Given this list of marker genes COX7B, APP, COX6A2, COX8A, COX8C, COX4I2, COX6B2, MT-CO1, MT-CO3, COX7A1, COX7A2L, COX7A2, COX6B1, COX4I1, COX5B, COX6A1, COX6C, COX7C, COX5A, MT-CO2, here is a description of the gene set: studied in species Homo sapiens Mutation-caused aberrant Abeta to electron transfer in Complex IV. Pathway ID: N00999. Pathway type: Variant. Pathway class: nt06460 Alzheimer disease. Human Gene Set: KEGG_MEDICUS_VARIANT_MUTATION_CAUSED_ABERRANT_ABETA_TO_ELECTRON_TRANSFER_IN_COMPLEX_IV Pathway Definition from KEGG: APP* -> Abeta -| CxIV -> H2O